The following is a description of a gene set: Human Gene Set: MYOD_Q6_01 Genes having at least one occurrence of the motif CNGNRNCAGGTGNNGNAN in the regions spanning 4 kb centered on their transcription starting sites. This matches the MYOD1 transcription factor binding site V$MYOD_Q6_01 (v7.4 TRANSFAC). species: Homo sapiens, and this is the list of marker genes: HOXC12, IMPDH1, NEURL1, SPCS1, WDR81, DCLK2, EPHA2, LDB3, CALB1, ATP1B1, MBD6 (methyl-CpG binding domain protein 6), LNX2, NADK2, CELA3B, CTR9, USP49 (ubiquitin specific peptidase 49), UBE2E1, PSIP1, IGF2BP1, TBR1, GRB2, IGF2-AS, AXIN2, CLSTN2, CACNA1H, PCGF1, SPACA6, SIM2, YARS1, ITGA11, CELA3A, SRRM3, TREX2, FCMR, SEMA3F, SORCS2, FSCN2, GRIK3, NOL4L, CA7, APBB1, DCLRE1C, ELAVL4, HMBOX1, GSK3B, RRAGC, CLC, KCNA4, HMGA1, SFTPC, GADD45G, HMGN2, CASKIN2, SERBP1, KRT8, CYP1A1, KCNK12, TRPV3, AFF4, MYCL, GPD1L, JPT1, SLC39A5, KLHL18, CYP26A1, SEZ6, CDH2, PITX3, SPAG9, KCNJ2 (NCBI Gene Id 3759), ACAP1, SLC44A1, RELCH, HYAL2, SH3GLB2, SMTNL2, DST, SGIP1, SPTAN1, LBX1, NKAIN4, TACR1, ARRDC3, MTX1, ACTN3, AGO1, WNT6, PPIF, SHKBP1, PRDM16, CREBBP (CREB binding protein), ARL4A, MYCLP1, PSD, WNT2B, POFUT1, GGN, SELL, AHI1, BCL6B (BCL6B transcription repressor), JMJD1C, JAZF1, DNAJC11, LEF1, HRH3, KCND3, ZFYVE9, NR4A1, DALRD3, KIF5B, NAA15, CPNE1, GPR37, POLR1D, SPEG, NUDT21 (nudix hydrolase 21), CDYL2, HSALR1, NHSL2, TMEM255A, KCNIP2, SP6, FHL3, ESCO1, CCDC85B, PRPH, PKN1, FBXO32, TSEN54, FGF11, PACSIN3, IRX6, RORC (NCBI Gene Id 6097), BMP7, IGF2, TFAP2C, SLC17A3, COQ10A, ZMAT3, POLR3GL, ARL8B, CD47, DMD, PPARA, ALG10, NDRG4, CYLD, ARL5B, USO1, GARRE1, MDGA1, ITGA6, NHLH1 (nescient helix-loop-helix 1), VGF, SPOP, SLC24A3, DSCAM, NFATC4, CADM1, PRSS12, ATXN7L2, EGR2, UBTF, ASB2, ZNF710, VPS13A, MXRA8, PRPF38B, RAB26, SIPA1, VDR, JSRP1, ACAA2, ZIC4, ANKRD2, IRX5, RUNX1T1, GRIN1, AGAP3, ARHGAP36, ARHGEF12, PLEC, CAMK2A, SMAD3, SOST, PARP8, ITPR2, TSC22D4, INTS9, GIT1, TFAP4, PPP2R2B, MIR22HG, BDNF, CLDN6, KCNQ4, PLAGL2, RNF128, DIDO1, GNB3, NDUFAF3, APBB2, DPCD, STMN1, ACTA1, HYCC1, TAFAZZIN, FHOD1, FZD5, GNAS, RCAN2, BMP1, SCG2, POU4F3, IKZF2, MT3, KCNH2, ELMO1, WDTC1, PAFAH1B1, CHRND, BCL7A, DOCK6, HBEGF, CSRNP1, USP32P2, AKAP12, TMEM165 (NCBI Gene Id 55858, transmembrane protein 165), CDK5R2, REL, KIF9, RNF213, WDR20, CKM, TCEAL7, PRKAG1, HID1, DGKD, ESRP2, TUBA4A, ERBB3, DCAF1, POLL, ZC2HC1C, GPR162 (NCBI Gene Id 553113), MLLT11, FOXP4, TMEM88, CFL1, FMNL1, CDC42SE1, ACOX3, FBRS, CORO2A, NCKAP5, ELAVL3, MYL6B, RUNX1 (RUNX family transcription factor 1), THBS3